Given this list of marker genes Shtn1, Kank1, Cyrib, Cfl1, Cdh5, Abl2, Llgl2, Kif3a, Rictor, Rack1, Gata3, Ankfn1, Tek, Rap1b, Wdpcp, Ripor2, Gsn, Dock8, Llgl1, Abl1, Igf1, Flot2, Plekhg3, Krit1, Rufy3, Arfgef1, Kif20b, here is a description of the gene set: species: Mus musculus Any process that modulates the frequency, rate or extent of the specification, formation or maintenance of anisotropic intracellular organization or cell growth patterns. Mouse Gene Set: GOBP_REGULATION_OF_ESTABLISHMENT_OR_MAINTENANCE_OF_CELL_POLARITY